The following is a description of a gene set: Any process that activates or increases the frequency, rate or extent of skeletal muscle cell differentiation. species: Mus musculus Mouse Gene Set: GOBP_POSITIVE_REGULATION_OF_SKELETAL_MUSCLE_CELL_DIFFERENTIATION, and this is the list of marker genes: Kat8, Tbx1, Mir675, Mef2c, Bmal1, Mcub, Gpc1, Cyp26b1, Rbm24